The following is a description of a gene set: Complex formation between p75NTR and RHOA can leads to inhibition of RHOA activity and axonal growth. studied in species Homo sapiens Reactome Pathway: Axonal growth stimulation part of: p75NTR regulates axonogenesis, and this is the list of marker genes: NGF, NGFR, RHOA, ARHGDIA